The following is a description of a gene set: Human Gene Set: GOCC_PROTEIN_PHOSPHATASE_4_COMPLEX species: Homo sapiens A protein serine/threonine phosphatase complex formed by the catalytic subunit of protein phosphatase 4 plus one or more regulatory subunits., and this is the list of marker genes: PPP4R3B, PPP4R3A, PPP4R1 (NCBI Gene Id 9989), PPP4C, PPP4R2, PPP4R3C